Given this list of marker genes ADORA1, GPLD1, BMP2, MTMR9, SRC, CHP2, here is a description of the gene set: Any process that activates or increases the frequency, rate or extent of removal of phosphate groups from a molecule. Human Gene Set: GOBP_POSITIVE_REGULATION_OF_DEPHOSPHORYLATION studied in species Homo sapiens